Given this list of marker genes NHERF4, NPPB, GUCA1B, NPPC, GNG7, GUCY2C, NPPA (natriuretic peptide A), NPR1, NPR2, GUCY2D, GUCY2F, here is a description of the gene set: Human Gene Set: GOBP_RECEPTOR_GUANYLYL_CYCLASE_SIGNALING_PATHWAY studied in species Homo sapiens The series of molecular signals initiated by an extracellular ligand binding to a receptor on the surface of the target cell where the receptor possesses guanylyl cyclase activity, and ending with the regulation of a downstream cellular process, e.g. transcription.